The following is a description of a gene set: Human Gene Set: GOBP_REGULATION_OF_CALCIUM_ION_TRANSMEMBRANE_TRANSPORTER_ACTIVITY Any process that modulates the frequency, rate or extent of calcium ion transmembrane transporter activity. studied in species Homo sapiens, and this is the list of marker genes: CACNB4, STIM1 (NCBI Gene Id 6786), HPCA, JPH2, STIMATE, UBQLN1, GNB5, AHNAK, STAC2, CBARP, CRACR2A, VMP1, CASQ1, SLN, PLN, NIPSNAP2, STAC, CALM2, CACNB3, STIM2, HAP1, CACNA1F, CRHR1, STAC3, HTT, SELENON, ATP2A1, GPR35, TLR9, CALM1, CAMK2D, ASPH (NCBI Gene Id 56921), FMR1, CALM3, STRIT1